The following is a description of a gene set: Human Gene Set: HP_ABNORMAL_OSSIFICATION_OF_THE_PUBIC_BONE studied in species Homo sapiens Abnormal ossification of the pubic bone Abnormal ossification (bone tissue formation) affecting the pubic bone, also known as the pubis., and this is the list of marker genes: FGFR2, GJB2, FIG4, NKX3-2, RUNX2, GSC, SIK3, COL2A1, CBFB, GJB6